The following is a description of a gene set: Neural crest cell migration during development Human Gene Set: WP_NEURAL_CREST_CELL_MIGRATION_DURING_DEVELOPMENT studied in species Homo sapiens, and this is the list of marker genes: EPHB1, CDH11, ARF1, PIK3R4, PAK1, NGEF, PAK6, EPHB4, EPHB6, PAK3, BDNF, RHOA, PIK3CG, MMP8, EPHB2, PIK3CD, TWIST1, PAK5, AKT3, F2RL2, EPHB3, JUN, PAK2, RAC1, NGFR, PIK3R5, PIK3CB, TIAM1, MMP2, AKT2 (NCBI Gene Id 208), BUB1B-PAK6, TRIO, STAT3, FOS, AKT1, PAK4, PIK3R6, PIK3R3, PIK3CA, MMP9